Given this list of marker genes STING1, CNGA2, PRKAR2A, RAPGEF4, PDE2A, CNBD2, SLC19A1, HCN1, PRKG2, HCN4, HCN2, PDE6H, POPDC2, PDE5A (phosphodiesterase 5A), KCNH1, PRKG1, PDE4A, PRKAR1A, PDE6G, CNGA3 (NCBI Gene Id 44), PDE4B, RAPGEF3, PDE6C, CNGA4, BVES, POPDC3, PRKAR2B, CNGB3, CNGA1, RAPGEF2, PDE11A (NCBI Gene Id 50940), PDE10A, PDE4D, HCN3, PRKAR1B, CNGB1, here is a description of the gene set: Binding to a cyclic nucleotide, a nucleotide in which the phosphate group is in diester linkage to two positions on the sugar residue. Human Gene Set: GOMF_CYCLIC_NUCLEOTIDE_BINDING species: Homo sapiens